The following is a description of a gene set: from publication Zhong S, Zhang S, Fan X, Wu Q, Yan L, Dong J, Zhang H, Li L, Sun L, Pan N, Xu X, Tang F, Zhang J, Qiao J, Wang X (PMID 29539641) Human Gene Set: ZHONG_PFC_C2_SOX5_BCL11B_POS_EXCITATORY_NEURON species: Homo sapiens, and this is the list of marker genes: VSNL1, SOX5, SERPINI1, PDE1A, HSPA1A, CNIH1, SHISA2, LMO7, SSBP2, PRKY, THSD7A, CNTNAP2, SERTAD4BP, ARG2, LSAMP, MASP1, ST18, RPS4Y1, BCL11B, LDHA, CAV1, IGFBP5, MGLL, CRYM (NCBI Gene Id 1428), FXYD7, EIF1AY, LMO3, CDH7